The following is a description of a gene set: Human Gene Set: HP_PROLONGED_BLEEDING_TIME Prolonged bleeding time species: Homo sapiens Prolongation of the time taken for a standardized skin cut of fixed depth and length to stop bleeding., and this is the list of marker genes: ITGA2B, CREB3L1, GFI1B, RIN2, NBEAL2, MYRF, BMS1, TP53, MPL, WIPF1, CD36, VWF, COL5A2, DTNBP1, GATA1, NF1, ITGB4, HPS5, GP1BA, TET2, COL1A1, MAP2K2, FYB1, COL5A1 (collagen type V alpha 1 chain), MYH9, PLEC, AGGF1, F5, AP3B1, SH2B3, GP1BB, PIK3CA, GP9, WAS, JAK2, F2 (coagulation factor II), GP6, RASGRP2, DLL4, ITGB3, UBA2, THBS2, ADAMTSL2, HPS6, HPS1, SLC35A1, ADAMTS2, CALR, GATA2, TEK, RUNX1 (NCBI Gene Id 861)